The following is a description of a gene set: Reactome Pathway: Cargo trafficking to the periciliary membrane part of: Assembly of the 9+0 primary cilium Proteomic studies suggest that the cilium is home to approximately a thousand proteins, and has a unique protein and lipid make up relative to the bulk cytoplasm and plasma membrane. In addition, the cilium is a dynamic structure, and the axoneme is continually being remodeled by addition and removal of tubulin at the distal tip. As a result, the function and structure of this organelle relies on the directed trafficking of protein and vesicles to the cilium. Small GTPases of the RAS, RAB, ARF and ARL families are involved in cytoskeletal organization and membrane traffic and are required to regulate the traffic from the Golgi and the trans-Golgi network to the cilium. ARF4 is a Golgi-resident GTPase that acts in conjunction with a ciliary-targeting complex consisting of the ARF-GAP ASAP1, RAB11A, the RAB11 effector FIP3 and the RAB8A guanine nucleotide exchange factor RAB3IP/RABIN8 to target cargo bearing a putative C-terminal VxPx targeting motif to the cilium. A well-studied example of this system involves the trafficking of rhodopsin to the retinal rod photoreceptors, a specialized form of the cilium. ARL3, ARL13B and ARL6 are all small ARF-like GTPases with assorted roles in ciliary trafficking and maintenance. Studies in C. elegans suggest that ARL3 and ARL13B have opposing roles in maintaining the stability of the anterograde IFT trains in the cilium. In addition, both ARL3 and ARL13B have roles in facilitating the traffic of subsets of ciliary cargo to the cilium. Myristoylated cargo such as peripheral membrane protein Nephrocystin-3 (NPHP3) is targeted to the cilium in a UNC119- and ARL3-dependent manner, while ARL13B is required for the PDE6-dependent ciliary localization of INPP5E. ARL6 was also identified as BBS3, a gene that when mutated gives rise to the ciliopathy Bardet-Biedl syndrome (BBS). ARL6 acts upstream of a complex of 8 other BBS-associated proteins known as the BBSome. ARL6 and the BBSome are required for the ciliary targeting of proteins including the melanin concentrating hormone receptor (MCHR) and the somatostatin receptor (SSTR3), among others. Both the BBSome and ARL6 may continue to be associated with cargo inside the cilium, as they are observed to undergo typical IFT movements along the axoneme. studied in species Homo sapiens, and this is the list of marker genes: GBF1, LZTFL1, MCHR1, CNGA2, BBIP1, TUBA3D, TUBA3C, PKD2, EXOC7, BBS2, TTC8, TUBA1A (NCBI Gene Id 95407), TUBB4B, BBS1, HDAC6, RAB3IP, UNC119B, BBS12, TUBB2A (NCBI Gene Id 92919), EXOC6, EXOC3, RAB8A, RP2, TUBA8, CCT8, TUBB2B, TUBB3, CCT5, TUBB8B, EXOC8, TUBB1, ARL13B, ARL6, BBS7, BBS9, BBS5, TUBB6, TUBA1C, RHO, NPHP3, CCT4, CYS1, TUBA3E, ASAP1, TUBA4A, SSTR3, RAB11A, PDE6D, TUBA1B, ATAT1, EXOC2, TUBAL3, PKD1, TUBB4A, TCP1, CNGA4, MKKS, CCT2, BBS10, SMO, EXOC1, EXOC5, CNGB1, ARF4, ARL3 (NCBI Gene Id 403), EXOC4, RAB11FIP3, CCT3, INPP5E, TUBB8, BBS4